Given this list of marker genes NFKBIZ, TNFRSF1B, VMO1, UBE2R2, BID, SNN, RHOC, HCK, PIK3AP1, SMCO4 (NCBI Gene Id 56935), RNPEP, RGS19 (regulator of G protein signaling 19), RIN1, CASP1, CSF1R, CHST15, WARS1, NEURL1, CPPED1, MS4A7, C15orf39, CLEC7A, LGALS9, TYROBP, PPP1R17, ZFAND5, PTPN6, GSTP1, C19orf38, LTA4H, NAP1L1 (nucleosome assembly protein 1 like 1), LST1, ITGAX, IRAK3, NCF2, SLC11A1, LILRA5, RAB10, UTRN, CDH23, DUSP1, ATP1B3, CD300E, MYO1G, GCH1, TCF7L2, CD300C, TLR4, TAGLN, MAFB, AMPD2 (adenosine monophosphate deaminase 2), FGD2, PECAM1, CD4 (CD4 molecule), GNS, CTSS, CD300A, SNX18, DMXL2, GPBAR1, HMOX1, LYN, RNF144B, CD300LF, ABI3, RARA, TBXAS1, CPVL, TNFSF10, CYBB, RHOB (ras homolog family member B), TNFSF13B, FCER1G, TSPAN14, RGS18, RELT, HES4, VMP1 (NCBI Gene Id 81671), MGAT1, LYST, SIGLEC10, MARCHF1, UNC93B1, LMO2, IFITM3, SERPINA1, C9orf72, ISG15, SIDT2, RXRA, CLEC12A, PHF19, ATP1A1, PILRA, CEBPB, SLC24A4, SH2D3C, NFAM1, NPL, LRRC25, NAAA, ADGRE1, SLC31A2, CNIH4, CXCL16, TYMP (NCBI Gene Id 4334), C5AR1, FTL, MYD88, TIMP1, KLF4, STXBP2, RRAS, FTH1, CFP, KYNU, BCL2A1, HES1, NBPF14, THEMIS2, PSAP, MTSS1, UNC119, FCGR3A, BRI3 (NCBI Gene Id 25798), SPI1, KLF3, FCN1, CUX1, LFNG, COTL1, INSR, ETS2, ATG3, P2RY13, FGL2, APH1B, FCGRT, ASAH1, PRAM1, ADGRE2, CD86, AP1S2, CMTM6, POU2F2, PAG1, SCIMP, ALDH3B1, NAGA, PAPSS2, ZNF703, KIAA0930, INSIG1, HK3, TTYH3, DUSP6, TCIRG1, MAP3K1, PLXNB2, ZEB2, LYPD2, SFMBT2, SAT1, FGR, EHBP1L1, CKB, CST3, SECTM1, OAS1 (2'-5'-oligoadenylate synthetase 1), HSBP1, SH3BP2, FAM110A, ZNF385A, NPC2, RNF13, TBC1D8, C1orf162, MPEG1, SLC7A7, S100A11, here is a description of the gene set: Human Gene Set: TRAVAGLINI_LUNG_NONCLASSICAL_MONOCYTE_CELL studied in species Homo sapiens from publication Travaglini KJ, Nabhan AN, Penland L, Sinha R, Gillich A, Sit RV, Chang S, Conley SD, Mori Y, Seita J, Berry GJ, Shrager JB, Metzger RJ, Kuo CS, Neff N, Weissman IL, Quake SR, Krasnow MA (PMID 33208946)